Given this list of marker genes Fadd, Tnfrsf10b, Traf2, Fas, Tnfsf10, Casp8, Cflar, Fasl, Tradd, Ripk1, here is a description of the gene set: Regulation by c-FLIP species: Mus musculus Mouse Gene Set: REACTOME_REGULATION_BY_C_FLIP